Given this list of marker genes CYP4F11, CYP4A22, CYP1B1, CYP4F2, CYP2U1, CYP1A2, CYP4F3, CYP2C9, CYP2C19 (cytochrome P450 family 2 subfamily C member 19), CYP2C8, CYP4A11, CYP1A1, here is a description of the gene set: studied in species Homo sapiens Human Gene Set: GOBP_OMEGA_HYDROXYLASE_P450_PATHWAY The chemical reactions and pathways by which arachidonic acid is converted to other compounds initially by omega-hydroxylation.